The following is a description of a gene set: studied in species Mus musculus Any process that activates or increases the frequency, rate, or extent of cell-cell adhesion mediated by integrin. Mouse Gene Set: GOBP_POSITIVE_REGULATION_OF_CELL_CELL_ADHESION_MEDIATED_BY_INTEGRIN, and this is the list of marker genes: Cd3e, Skap1, Podxl, Cxcl13 (C-X-C motif chemokine ligand 13), Piezo1, Ccl5, Cd24a (NCBI Gene Id 12484)